The following is a description of a gene set: species: Homo sapiens Neighborhood of HDAC1 histone deacetylase 1 in the GCM expression compendium Neighborhood of HDAC1 Human Gene Set: GCM_HDAC1, and this is the list of marker genes: NONO, CBFB, DDB2, ARHGEF1, TCEA1, PRMT1, PSME1, SIGMAR1, HMGN1, HNRNPL, HDAC1, HNRNPD, SCAF11, GPSM3, AIP, DRAP1, PRKAG1 (NCBI Gene Id 5571), ILF2, MEN1, RPL21, PFN1, ESD, SRSF2, NCL, ATP5PB, EIF4B, TIMM17A, ANXA6 (NCBI Gene Id 309), NASP, SRSF9, SLC25A3, NDUFA12, ANP32B, HNRNPM, APEX1, LMNB2, SRSF3, SET